Given this list of marker genes IDUA, MADD, NFIC, NEFL, INPP5J, NTHL1, MAPK3, CENPI, PNMT, TTF1, SIGMAR1 (NCBI Gene Id 80768), PSG7, DRG2, AANAT, ADRB3, PRKCG, KRT32, WAS, COX10, RAB33A, ASMT, CD8B, ZNF8, FCGR2A, ADCYAP1, HTT, KRT6C, TMEM106A, MIEF1, TIMM17A, COL14A1, ABCC1, TH, CCR9, SLC29A2, AVPR1B, TTC1, CSN3, APOC3, NUP188, SCNN1G, SDHC (succinate dehydrogenase complex subunit C), AQP7, ZNF76, MAPRE1, SLC16A1, TMEM94, FUT2, KRT31, MICB, PDE6B, GCGR, AAMP, CHIC1, SUPT4H1, LYST, RABGGTA, HMGA2, PMS2P11, MYH7 (NCBI Gene Id 8090), DPF2, PRKAG1, DGCR6, DDX18, BNIP1, SIRPB1, FEV, FANCC, SP2, SLC2A4, MPP2, BCAT2, GH2, MYBPC2 (NCBI Gene Id 9115), STIM1, RENBP, TLK2, BDH1, HTR1E, KRT35, GSTZ1, NGFR, SLC18A1, AQP2, SF1, GRM4, NRF1, TRIP13, RNPS1, LTK, DRD1, SMARCD1, GPER1, IGKV7-3, PLK1, GPR3, SMARCD2, TAF1 (TATA-box binding protein associated factor 1), VPS72, BECN1, ZNF134, IKBKE, GJA5, ERV3-1, MVK, TEC, PTPN5, RING1, REG1CP, ODF1, GLA (galactosidase alpha), EBI3, here is a description of the gene set: studied in species Homo sapiens Neighborhood of RING1 Human Gene Set: GCM_RING1 Neighborhood of RING1 ring finger protein 1 in the GCM expression compendium